Given this list of marker genes Mapk8ip3, Dnah9, Iqub, Htt, Kif3c, Cluap1, Catsperz, Nme5, Dynlt5, Drc1, Sun1, Tekt3, Nme8, Bbs12, Dnah14, Ttll5, Zmynd12, Gk2, Myo5a, Dnah8, Celf3, Kifc1, Tektip1, Ift172 (NCBI Gene Id 67661), Lca5l, Bloc1s6, Dynlt4, Dync2h1, Cfap73, Rab17, Cfap95, BC048507, Nefl, Dnajb13, Wdr35, Klc2, Ccdc146, Katnip, Kif1a, Slc9b1, Yif1b, Inpp5b, Cfap276, Kif5a, Kif19b, Dydc1, Klc1, Fbxw11, Tacr3, Kif13a, Hspa8, Cfap119, Armc3, Kif15, Hap1, Actr3, Ndel1, Pafah1b1, Tmem232, Ap3s1, Actr2, Nefh, Cfap107, Tex101, Cabs1, Fez1, Dynlrb1, Wdpcp, Nefm, Cfap70, Efhb, Vdac3, Spag6, Lamp1, Tekt1, Pldi, Arl8b, Dnaaf3, Bloc1s2, Tnp2 (NCBI Gene Id 21959), Cfap144, Chrna7, Kpnb1 (NCBI Gene Id 16211), Tmem201, Ift46, Ift22, Tbc1d21, Syne2, Agbl4, Kif7, Irgc, Cfap58, Dnai7, Rab21, Dst, Rabl2, Lztfl1, Cep78, Cacna1e, Ap3m2, Cdc42 (cell division cycle 42), Spg7, Cfap52, Tnp1, Prdm14, Cfap141, Poc1b, Spast, Rnase9, Adam7, Sord, Slc22a14, Intu, Ift122, Kif27, Cfap20, Ccdc39, Cfap54, Efcab6, Cyb5d1, Catsper1, Defb37, Defb1, Rhot2, Dtnbp1, Klc4, Nherf1, Kif26a, Dnah12 (dynein, axonemal, heavy chain 12), Copg2, Anxa5, Map1b, Dnah11, Stard7, Ldhc, Atp1a4, Kif2b (kinesin family member 2B), Wasf1, Cimap1a, Garin5a, Spmip5, Dync2li1, Spg11, Gapdhs, Arhgap21, Wdr19, Ift70a2, Atg5, Kifc5b, Spmip10, Tac2, Pgk2, Mecp2, Tmem230, Cfap161, Nde1, Dnai1, Insl6, Sfpq, Kifap3, Mst1, Dlg2, Wt1, Dnaaf1, Uchl1, Stk36, Rnase10, Stard9, Armc2, Ulk4, Cfap61, Pex14, Dnah5, Lrrc46, Adcy10, Rab1a, Ccnyl1, Drc7, Ap3b1, Madd, Dnah1, Kif6, Fuz, Dnaaf6, Pla2g3, Dynll1, Ints13, Arl3, Cfap57, Kif1b, Tac4, Spata33, Mns1, Septin4, Kif20a, Borcs6, Bicd1, Fsip2, Kif18b, Enkur, Spef2, Cimip2b, Sod1, Slirp (SRA stem-loop interacting RNA binding protein), Ift56, Catsper3, Borcs8, Ubb, Snapin, Cfap44, Lca5, Prm3, Wfdc6a, Efcab9, Ift52, Map2, Copg1, Catspere2, Kif3b, Wfdc6b, Nsun7, Rab27b, Bbs1, Armcx3 (armadillo repeat containing, X-linked 3), Pltp, Actr10, Hif1a, Slc9b2, Eno4, Odad4, Tub, Bbs4, Mgarp, Cfap45, Bbs2, Rhot1, Kif22, Dync1i1, Spmip8, Spag6l, Cep131, Ccdc88c, Smcp, Qrich2 (NCBI Gene Id 217341), Hnrnpu, AU040320, Rsph3b (NCBI Gene Id 100037282), Garin2, Odad1, Dynlt3, Dzip1, Sun2, Dnai3, Ift20 (NCBI Gene Id 68335), Tmf1, Garin5b, Ttll8, Ofd1, Dnaja1, Prss55 (serine protease 55), Ropn1, Dnah2, Cilk1, Rhox5, Cfap47, Rsph6a, Ank3, Fmn2, Catsperd, Tssk4, Ift88, Kif2c, Rfx3, Mapt, Kif28, Taf7l, Kif17, Dnai4, Kifc2, Prkcz, Met, C2cd6, Cfap53, Apob (NCBI Gene Id 238055), Catsper2, Meig1, Iqcg, Ift27, Dnah7a, Ap3d1, Ttc21a, Spmip6, Txndc2, Spinkl, Gas2l2, Tcte1, Hsbp1, Cfap65, Hspb1, Cenpe, Pacrg (PARK2 co-regulated), Cfap68, Spaca9, Ash1l, Hoatz, Cwh43, Kif16b, Ktn1, Neto1, Ift43, Jhy, Kif20b, Ak7, Tssk6, Cfap90, Kif9, Ift57, Ap3s2, Atg16l1, Bbof1, Kif14, Kif12, Pierce1, Akap3, Pdcl2, Trim46, Ribc2, Dnai2, Cfap251, Cfap91, Ap3m1, Dusp21, Terf2, Stau1, Cfap206, Misfa, Adcy3, Borcs7, Tacr2, Odad3, Cln3, Tubb4b (tubulin, beta 4B class IVB), Sybu, Dpcd, Ssx2ip, Caly, Ribc1, Stau2, Rgn, App, Tekt2, Map1a, Ift25, Pfn4, Nphp4, Bicdl2, Dync1h1, Dnah6, Saxo4, Slc9c1, Cfap69, Dync1i2, Rsph9, Dnah10, Efhc2, Bicdl1, Ttll1, Kif1c, Nme7, Flot2, Tmem108, Traf3ip1, Cfap157, Dnaaf5, Armc12 (armadillo repeat containing 12), Ddx4, Ift74, Cfap221, Tekt5, Spem1, Ing2, Adam3, Ly6k, Kif26b, Ttll9, Dnali1, Kifbp, Kif2a, Neurl1a, Clxn, Ccr6, Cep128, Trak1, Kif18a, H1f6, Cfap43, Gmnc, Kxd1, Eppin, Gas8, Ift80, Dnaaf4, Cnih2, Ropn1l, Vps13a, Tpgs1, Dynlt1b, Dync2i2 (NCBI Gene Id 71820), Ift81, Cfap100, Dync1li1, Rsph1, Tac1, Bloc1s5, Dynlrb2, Kif3a (NCBI Gene Id 192824), Kif24, Rsph14, Hdac6, Klc3, Ttll3, Clip3, Map2k1, Garin3, Or4m1, Ssna1, Kif21b, Cfap210, Celsr2, Ccdc63, Pcm1, Cfap298, Kif11, Ccdc40 (coiled-coil domain containing 40), Dnhd1, Spef1, Cimip2c, Dnah3 (dynein, axonemal, heavy chain 3), Tacr1, Tppp2, Camsap3, Kif19a, Lrrc23 (leucine rich repeat containing 23), Ap3b2, Catsper4, Iqcf1, Daw1, Ttc12, Ccdc38, Dynlt2b, Bsn, Aqp4, Spem3, Dnaaf2, Bloc1s3, Map6, Cfap97d1, Cimip2a, Kif13b, Invs, Odad2, Kif23, Rabgef1 (NCBI Gene Id 56715), Ttll6, Vangl1, Dync2i1, Megf8, Bloc1s1, Dnah7b, Ttc29, Kif4, Pierce2, Cabcoco1, Slc22a16, Kif21a, Cfap126, Catspere1, Kif5b, Kifc3, Dnaaf11 (dynein axonemal assembly factor 11), Stk11, Hydin, Bicd2, Ift70b, Rsph4a, Ttc21b, Tekt4, Mak, Arl8a, Zmynd10, Katnb1, Trim58, Tektl1, Iqcn, Ift140, Bloc1s4, Spag17, Ift70a1, Atp2b4, Fyco1, Spag16, Efhc1, Spmip9, Kif5c, Ube2b (ubiquitin-conjugating enzyme E2B), Rpgr, Pura, Dnah17, Ccdc159, Dnaaf6rt, Dynlt2a1, Trak2, Rasgrp1, Mkks, Dusp3, Dnah7c, Akap4, Ccdc103, Agtpbp1, Tuba1a, Dync1li2, Map4, Nek10, Borcs5, Ccdc65, Mreg, Spag8, here is a description of the gene set: species: Mus musculus A microtubule-based process that results in the movement of organelles, other microtubules, or other cellular components. Examples include motor-driven movement along microtubules and movement driven by polymerization or depolymerization of microtubules. Mouse Gene Set: GOBP_MICROTUBULE_BASED_MOVEMENT